Given this list of marker genes Bcat2, Mecp2, Vars2, Gldc, Srr, Adss1, Ppat, Plod2, 4930438A08Rik, Pfas, Enoph1, Slc1a3, Auh, Qrsl1, Tdh, Fars2, Got2 (glutamatic-oxaloacetic transaminase 2, mitochondrial), Nmnat2, Egln2 (egl-9 family hypoxia-inducible factor 2), Amt, Iyd, Oat, Bckdha, Slc38a8, Sardh, Aspg, Mri1, Cth, Aadat, Shmt1, Lao1, Fpgs (NCBI Gene Id 98767), Nadsyn1, Hmgcll1, Amdhd1, Ahcy, Aldh18a1, Ido2, Acmsd, Nr1h4, Adi1, Dbt, Hars1, Qars1, Sephs2, Carnmt1, Lrrc47, Tyrp1 (NCBI Gene Id 22178), Dars2, Adhfe1, Mmut, Agmat, Csad, Nit2, Agxt, Vars1, Asrgl1, Dalrd3, Pipox, Azin2, Slc16a2, Fh1, Iars2 (isoleucine-tRNA synthetase 2, mitochondrial), Pycr1, Slc7a11, Crtap, Mpst, Accsl, Sars1, Gart, Cln3, Agxt2, Aarsd1, Upb1, Kyat1, Azin1, Prodh, Glul, Ttc36, Atp2b4, Ilvbl, Cyp2d22, Gcsh, Apip, Otc, Glud1, Kynu, Dars1, Dio1, Scly, Dpyd, Aldh4a1, Gls, Mthfr, Cps1, Lgsn, Bckdhb, Nos2, Psph, Ddah1, Gatb, Mthfd1, Iars1, Aars1, Mthfd2l, Slc38a1, Asns, Cad, Slc39a8, Mars1, Odc1, Tars2, Ggt5, Haao, Hibadh, Bckdk, Ftcd, Spr, Prodh2, Dpep1, Tph1, Mtr, Pycr2, Sars2, Gpt, Thap4, Kyat3, Dct, Bhmt2, Mthfsl, Sephs1, Qdpr, Pah, Asnsd1, Rars1, P4ha1, Mtap, Th, Atcay, Tha1, Thnsl2, Mccc2, Aasdh, Hpd, Nos3, Gcat, Pcmt1, Park7, Gad2, Pcbd2, Cdo1, Carns1, Rars2, Ins2, Nat8l, Pars2, Aspa, Shmt2, Hao1, Oaz1, Cbs, Slc25a2, Sirt4, Lars1, Tars3, P4ha2, Dlst, Gnmt, Mccc1, Slc25a44, Tdo2, Ears2, Yars1, Hal, Ido1, Ahcyl, Ldc1, Ero1b, Etfa, Kars1, Gpt2, Aars2, Nags, Glyat, Abat, Hars2, Asl, Bloc1s6, Dld, Ass1, Gstz1, Arg2, Bhmt, Tars1, Ins1, Bhmt1b, Farsb, Hibch, Aldh6a1, Mat1a, Hoga1, Yars2, Ndp, Pycr3, Mars2, Wars1, Baat, Acad8, Ggt1, Uroc1, Gatc, Ppm1k, Slc25a12, Accs, Nos1, Acadsb, Plod3, Aldh5a1, Atf4, Gars1, Gclc, Hnf4a, Gad1, Tph2, Mtrr, Aldh8a1, Comt, Aldh1a1, Lars2, Kmo, Blmh, Ddo, Slc7a7, Ddc (NCBI Gene Id 13195), Nox4, Txnrd1, Mcrip2, Aass, Gfpt2, Fah, Acat1, Noxred1, Slc45a2, Ucp2, Got1, Qprt, Oca2, Htt, Wars2, Hpdl, Dglucy, Aasdhppt, Acy1, Pm20d1, Cars1, Icmt, Il4i1, Nars2, Got1l1, Gamt, Dao, Atp7a, Etfb (NCBI Gene Id 72756), Cars2, Phgdh, Prdx4, Apc, Gclm, Eprs1, Hdc, Farsa, Pcbd1, Sdsl (NCBI Gene Id 70795), Hgd, Psat1, Afmid, Hmgcl, Hsd17b10, Gls2, Arg1, Dpys, Ivd, P4hb, Tat, Sds, Gcdh, Adss2, Pemt, Ero1a, Nars1, Bcat1, here is a description of the gene set: Mouse Gene Set: GOBP_AMINO_ACID_METABOLIC_PROCESS The chemical reactions and pathways involving amino acids, carboxylic acids containing one or more amino groups. studied in species Mus musculus